The following is a description of a gene set: Any process that modulates the frequency, rate or extent of signaling via a stress-activated protein kinase signaling cascade. studied in species Mus musculus Mouse Gene Set: GOBP_REGULATION_OF_STRESS_ACTIVATED_PROTEIN_KINASE_SIGNALING_CASCADE, and this is the list of marker genes: Nbr1, Il1b, Ppia, Zmpste24, Tlr4, Hmgcr, Ripk2, Gstp1, Inava, Sema4c, Il1a, Taok3, Map3k20, Grem1, Tgfb2, Card9, Dusp10, Eif2ak2 (NCBI Gene Id 76759), Mapk3, Nod1, Mapk1, Nod2, Igfbp6, Pbk, Taok1, Stk25, Mid1, Foxm1, Qars1, Arl6ip5, Map2k1, Crhr2, Taok2, Foxo1, Prdx1, Pdcd10, Clec7a, Klhdc10, Fas, Mapk8ip2 (NCBI Gene Id 97995), Map2k2, Scimp